The following is a description of a gene set: Human Gene Set: GSE8685_IL2_STARVED_VS_IL2_ACT_IL2_STARVED_CD4_TCELL_DN In this study we compared the effects of IL-2, IL-15, and IL-21 on the gene expression, activation of cell signaling pathways, and functional properties of cells derived from the CD4+ cutaneous T-cell lymphoma (CTCL). Whereas both IL-2 and IL-15 that signal through receptors that share the common gamma chain and the beta chain modulated the expression of >genes, IL-21 that signals via the receptor also containing gamma chain up-regulated <genes. All three cytokines induced tyrosine phosphorylation of Jak1 and Jak3. However, only IL-2 and IL-15 strongly activated STAT5, PI3K/Akt, and MEK/ERK signaling pathways. In contrast, IL-21 selectively activated STAT3. Whereas all three cytokines protected CTCL cells from apoptosis, only IL-2 and IL-15 promoted their proliferation. The effects of the cytokine stimulation were Jak3- and Jak1-kinase dependent. These findings document the vastly different impact of IL-2 and IL-15 vs. IL-21 on malignant CD4+ T cells. They also suggest two novel therapeutic approaches to CTCL and, possibly, other CD4+ T cell lymphomas: inhibition of the Jak1/Jak3 kinase complex and, given the known strong immunostimulatory properties of IL-21 on CD8+ T, NK, and B cells, application of this cytokine to boost an immune response against malignant CD4+ T cells. from publication Marzec M, Halasa K, Kasprzycka M, Wysocka M, Liu X, Tobias JW, Baldwin D, Zhang Q, Odum N, Rook AH, Wasik MA (PMID 18281483) studied in species Homo sapiens Genes down-regulated in Sez-2 cells (T cell lymphoma): untreated versus IL2., and this is the list of marker genes: PHLDB2, POLR1A, ZFP41, SRRM1, MTM1, SCOC, UBE2Q2, NEDD4, SRD5A1, CLTA, FANCB (NCBI Gene Id 2187), FRRS1, KIFAP3, TKT, IDH3A, GCLM, DOCK1, KPNA2, SEC24D, FUT8, CNNM2, DHX9, SNHG32, CCDC137, TOMM6, SCML2, POLR1D, GORASP2, GAB2, CDCA2, NEO1, CRELD2, DNMT1, MAPK7, BSN, CCDC18, RNF157, ELANE, CSF3R, LRRC58, PKIB, TIMELESS, CDH1, ESCO2, ASF1B, CENPM, ERLIN1, LUC7L3, QTRT2, GMDS, KPNB1, CACNA1D, SERPINF1, PRIM2, ZNF330, ERLIN2, SEPHS1, NEK2, GFI1, TBC1D32, DTWD1, CTC1 (CST telomere replication complex component 1), IL1R1, KRR1, DKC1, CCDC34, NSD2, ELP1, ICA1, CREG2, SLC22A3, BRI3BP, SNX9, NAT8L, STX3, POLA2, RNF7, RNASEH2B, ABCC4, C1GALT1C1, CSTF3, DAGLB, EEPD1, C4orf19, ZWILCH, GMPR, RBM44, RFWD3, KBTBD13, DCLRE1B, PSME4, OAF, SDF2L1, EME1, THG1L, RRM1, CKAP2L, RACGAP1, ALDH2, SNHG3, ADAM9, UMOD, MORF4L1, USP11, MMP2, TBC1D2B, ZDHHC5, NUP43, FAM98B, SH3D19, POLR1F, CCNA2, VAPA, TYMS, KIAA1549, LEO1, MED6, SSX2IP (NCBI Gene Id 22892), ENOPH1, TRIM35, RAB11FIP5, NPM1, GABRP, SOX12, ZNF446, IL15, HSD17B1, DEPTOR, DOLK, HNRNPU, UNC5B, CPNE2, API5, MAPK8, BID, SPAG5, MACROH2A1, SLC31A1, DBI, PARL, CDC14A, MEIS1, IL11RA, RAD54B, FNIP1, C12orf42, GANC, MOSPD2 (NCBI Gene Id 158747), GOT2, TBC1D24, FUCA2, HROB, MIER3, IFTAP, DEPDC1, TERB2, KRTAP2-4, C6orf62, MIS18BP1, TMEM144, SERBP1 (NCBI Gene Id 51624, SERPINE1 mRNA binding protein 1), AGL, RNF144B (NCBI Gene Id 255488), PCM1, TM6SF1, CDK2AP1, PXT1, FADS2, ZBED5, EIF4H, RPGR, G6PD, UGDH, SEC23B, RAI14, SKA3, TMEM38B, CES5A, GLIPR1, CAAP1, FAM111A, IREB2 (iron responsive element binding protein 2), IMPA1 (inositol monophosphatase 1), PDE6D, SPNS2 (NCBI Gene Id 124976), TMEM8B, MDM1, IMPDH2, FAM184A, SEPHS2, RUSF1, OAZ1, CKAP2, RELL1, MANEA, HPSE, HDLBP, HMGA2